The following is a description of a gene set: Human Gene Set: CHARAFE_BREAST_CANCER_LUMINAL_VS_BASAL_DN Genes down-regulated in luminal-like breast cancer cell lines compared to the basal-like ones. A better molecular characterization of breast cell lines (BCL) may help discover new markers to apply to tumour samples. We performed gene and protein expression profiling of 31 BCL using whole-genome DNA microarrays and immunohistochemistry (IHC) on 'cell microarrays' (CMA), respectively. Global hierarchical clustering discriminated two groups of BCL: group I corresponded to luminal cell lines, group II to basal and mesenchymal cell lines. Correlations with centroids calculated from a published 'intrinsic 500-gene set' assigned 15 cell lines as luminal, eight as basal and four as mesenchymal. A set of genes was differentially expressed between basal and luminal samples. Mesenchymal and basal subtypes were rather similar and discriminated by only genes. The expression of 10 proteins (CAV1, CD44, EGFR, MET, ETS1, GATA3, luminal cytokeratin CK19, basal cytokeratin CK5/6, CD10, and ERM protein moesin) encoded by luminal vs basal discriminator genes confirmed the subtype classification and the validity of the identified markers. Our BCL basal/luminal signature correctly re-classified the published series of tumour samples that originally served to identify the molecular subtypes, suggesting that the identified markers should be useful for tumour classification and might represent promising targets for disease management. from publication Charafe-Jauffret E, Ginestier C, Monville F, Finetti P, Adélaïde J, Cervera N, Fekairi S, Xerri L, Jacquemier J, Birnbaum D, Bertucci F (PMID 16288205) studied in species Homo sapiens, and this is the list of marker genes: FAP, PALM2AKAP2, NDEL1, MMADHC, GNG12, SRI, SLC9A6, RALB, TLE4, MYO1B, AKR1C3, TWIST2, COL4A1, UBASH3B, MICALL1, CASP4, IRS2, IFNGR1, TWSG1, ESYT2, RHOA, ANKH, ADM, SLC1A3, STAMBPL1, HRH1, TP63, HMGA2, RETSAT, FRMD6, SEPTIN10 (septin 10), LOX, CDC42EP3, PDP1, FAS, KIRREL1, ST3GAL6, GNAL, BMAL2, IL1RAP (interleukin 1 receptor accessory protein), LAMC2, B2M, CCDC28A, ITGA1, SH3KBP1, SPATS2L, KRT15 (keratin 15), RUNX3, B3GNT5, CDK6, AMD1, AKT3, DEPP1, NNMT, ARHGEF28, LAMA3, TAX1BP3, RIOK3 (NCBI Gene Id 8780), CTSC, PKN2, PDZK1IP1, FHL1, CCDC88A, MT2A, PXDC1, MME, IGFBP6, BTG3, NR3C1, MTMR2, F2RL1, MIR31HG, CDH3, PHLDB2 (pleckstrin homology like domain family B member 2), GBP3, SLC49A4, KLHL29, ANXA2P2, DST, SFRP1, HTRA1, SNX7, CAVIN1, ZC3H12C, OGFRL1, GLIPR1, FOXQ1, COPS8, PIK3CD, IGFBP7 (NCBI Gene Id 3490), SAMD9, GPSM2, ADORA2B, NSFL1C, SFN, INHBA, ARHGAP23 (NCBI Gene Id 57636), IRX1, YBX3, CALD1, PKP2 (plakophilin 2), MMP14, ANXA2, PTPRM, MAML2, NXN (nucleoredoxin), LY6K, ANXA8, NUP50, PTK7 (NCBI Gene Id 5754), VSNL1, IGF2BP2, KRT6B, TKT, FOSL1, PRKD3, INPP1, AXL (NCBI Gene Id 558), FZD6, CYB5R3, WWTR1, PRSS12, RNF145, CARD6, MSN, CLIP4, IL20RB, STK17A, NKX1-2 (NK1 homeobox 2), NUDT15, IFI16, LYN, NFE2L2, KRT16, DSG3, ALDH3A2, IL18 (interleukin 18), PSAT1, FDFT1, DSG2, CFL2, PPP1R14C, F3, IL7R, GPM6B, PLA2G4A, DIPK1A, ITGA6, RGCC, IGF2BP3, IL15, SRPX2 (NCBI Gene Id 27286), PM20D2, CCNYL1, MT1X, SVIL, KRT5, CAVIN3, WDR1, CEBPD, DPYD, APOL6, PLSCR1, FAM83A, ITPRID2, PPP4R1, LAMC1, TGFBI, MDH1, CYBRD1, ALDH1A3, GART, SRPX, CRK (CRK proto-oncogene, adaptor protein), CAV2, TBPL1, EVA1A, FMNL2 (NCBI Gene Id 114793), ORMDL1, TMED5, SIRPA, MFGE8, LIPG, DSE, CD109, GABRE, ADD3, PTPN2, PARP4, SAA1, TMEM245, SOAT1, KLF5, CCNA1, HIF1A, RRAS2, GM2A (NCBI Gene Id 2760), MBP, HSD17B11, DGKA, HRCT1, ATP1B3, COL4A2, CHMP1B, PNLIPRP3, TMEM30A, CFLAR, TRIM29, SLC16A1, VAMP3, LINC01133, GAS1, MET, ABCD3, NFAT5, SH3D19, SP100, MAP7D3, CFB, ARHGAP5, HP1BP3, KLK5, CAMTA1, GFOD1, GTF2B, WLS (Wnt ligand secretion mediator), ADRB2, DOCK5, FKBP1A, TRIP10, FGF2, PGM2, CBR1, ETS2, MPZL1, RBMS1, DCBLD2, PI3, CSNK2A2, S100A2, RGS20, PSMB9, CRYAB, GSTP1, OSMR, IFI44, LUZP1, PRNP, SLC25A37, BIRC3, CYLD, RAC2, ARPC2, IFI27, NABP1, GJC1, ELL2, CHST3, TM2D1, FAM83D, SMCHD1, CRYBG1, MIR22HG, ETF1, PSMB8, IL1A, GALNT2, ZBTB38, BTN3A3, EMP1, MYL12A, BTN3A2, OSBPL3, CMPK1, FSCN1, EMP3, IFIT3, ANXA3, TNFAIP3, CLMP, ADGRE5, DNAJB4, TBC1D1, UPP1, AKR1B10, CORO1C, TAP2, ARAP3, NDFIP2, CD59, CASP1, MBNL1 (NCBI Gene Id 9850), RBMS3, DSC3, C3, MIR100HG, EVA1C, DMD, CXCL1, HLA-E, CCDC80, PDGFC, ANKRD33B, CCDC9B, GNA15, P3H2, ETS1, NRP1, FST, OSBPL9, NT5E, RND3, BMP1, SPX, CCDC82, ITM2C, ICAM1, GJB3, TNFRSF10D, SNAI2, ATP10D (ATPase phospholipid transporting 10D (putative)), REXO2, YES1, SLC16A7, RIPK4, LARP6, STAT4, MYO1E, NMI, GNAI1 (G protein subunit alpha i1), BICC1, CD58, NAMPT, RGL1, C1S, LOXL2, PLAT, TNFAIP8, EGFR, KLK10, CRIPT (NCBI Gene Id 9419), RALBP1, DCTD, CD14, ASXL1, PTGS2, LINC00511, ACTN1, CIBAR1, RBFOX2, BICD2, PLS3, RBM7, C1R, LAMB3, KIF1B, DUOX1, AKR1C1, TCEAL9, SLPI, ITGB8, TUBB6, JAG1, SELENOF, CXCL3, ADA, FNDC3B, TMEM35B, UBE2E3, SLC6A15, ANXA1, CFI, TUBA4A (NCBI Gene Id 93373), SOX7, KRT14, HOXA5, ELK3, HOTAIRM1, NAP1L1, ITGB1, ZDHHC2, CD44, SERPINB2, MT1G, MBNL2, LBH, CAV1, TOX2, FAM171A1, RGS2, NAB1 (NGFI-A binding protein 1), NCK1, SPTBN1, OXR1, SPRY2 (sprouty RTK signaling antagonist 2), TMEM154, YAP1, STING1, CLIC4, ERAP2, KRT17, FGFBP1, EPHA2, KRT6A, GBP1, CDCP1, SH3GLB1, STAT3, HOXA1, CXCL2, ANTXR1, MT1F, ZBTB16, SCHIP1, TGFBR2, SCPEP1, RFLNB, FBLIM1, EHBP1, SGK1, COTL1, SMAD3, PERP, ANXA4, AKR1B1, FXYD5 (FXYD domain containing ion transport regulator 5), GPX8, PLAU, DCBLD1, HOXA3, AGPS, KPNA1, COL8A1, TGFA, SIRPAP1, MT1H, SERPINE2, NAV2, EXT1 (exostosin glycosyltransferase 1), FERMT1 (NCBI Gene Id 55612), IFITM3P7, TRMT6, MAP4K4, SERPINB5, BNC1, ATP1A1, BIN1 (bridging integrator 1), NOB1, EREG, MDFIC, SEL1L3, TLR2, FSTL1, SKAP2, TRIM22, YBX1